The following is a description of a gene set: Genes down-regulated in dendritic cells versus macrophages sorted as ITGAX int and EMR1 high. from publication Rivollier A, He J, Kole A, Valatas V, Kelsall BL (PMID 22231304) Dendritic cells (DCs) and macrophages (MPs) are important for immunological homeostasis in the colon. We found that F4/80hi CX3CR1hi (CD11b+CD103-) cells account for 80% of mouse colonic lamina propria (cLP) MHC-IIhi cells. Both CD11c+ and CD11c- cells within this population were identified as MPs based on multiple criteria, including a MP transcriptome revealed by microarray analysis. These MPs constitutively released high levels of IL-10 at least partially in response to the microbiota via an MyD88-independent mechanism. In contrast, cells expressing low to intermediate levels of F4/80 and CX3CR1 were identified as DCs, based on phenotypic and functional analysis and comprise three separate CD11chi cell populations: CD103+CX3CR1-CD11b- DCs, CD103+CX3CR1-CD11b+ DCs and CD103-CX3CR1intCD11b+ DCs. In non-inflammatory conditions, Ly6Chi monocytes differentiated primarily into CD11c+, but not CD11c- MPs. In contrast, during colitis, Ly6Chi monocytes massively invaded the colon and differentiated into pro-inflammatory CD103-CX3CR1intCD11b+ DCs, which produced high levels of IL-12, IL-23, iNOS and TNF. These findings demonstrate the dual capacity of Ly6Chi blood monocytes to differentiate into either regulatory MPs or inflammatory DCs in the colon, and that the balance of these immunologically antagonistic cell types is dictated by microenvironmental conditions. studied in species Homo sapiens Human Gene Set: GSE27859_DC_VS_CD11C_INT_F480_HI_MACROPHAGE_DN, and this is the list of marker genes: CCT2, TOMM20 (translocase of outer mitochondrial membrane 20), DIP2A, CLN6, BANK1, CGGBP1, TCF7L2, EIF4EBP2, TTC7A, GET3, CTPS1, MRPL41, ATP5IF1, TMEM205, CES2, CATSPERD, VEGFB, SIKE1, MAN2A1, OSBPL7, MAP1LC3A, PMPCA, SAMM50, C1QBP, RNF4, ELMO1, PPARG, MST1, PIGM, ALDH9A1, AP4E1, UBFD1, RASSF5, SMC4, UCHL3, SUCLG2, CLASP1, FBXO5, TMX3, SPCS2, SVIP, ACAP3, PHF3, PPP1R7, HMGN2, RPL29, TSPAN32, CAMK1, SPAG11B, CALM3, LPCAT3, SLC16A9, MRPL39, CENPN, SFXN1, SLC25A36, SGCB, HSPA9, MBNL3, SORT1, SORD, NAPEPLD, INPP5A, ADIPOR1, BLVRA, SPSB2, EXOSC5 (NCBI Gene Id 56915), SLC22A18, FKTN, NLN, TSPAN14, GPR137B, RPP40, FBXO36, ATXN10, FGD4, MYO5A, CDC34, NR2F6, TCEAL9, GFI1B, COPZ2, NEK6 (NIMA related kinase 6), SAMD5, SFT2D1, RAB1B, TMEM141, ETHE1, RPL35A, ACD, EIF3H, MAOA, ADGRL2, ACAA2, NRG4 (NCBI Gene Id 145957), ANAPC10 (NCBI Gene Id 25866), KYAT3, ANP32E, ZHX1, ALDH1L1, IL18, EMC2, PDXK, PLIN3, GNL3L, RPS6KB1, AURKAIP1, NSUN3, SNX15, CD24, TERF2, PSAT1, ANO6, ATP6V0D2, PRMT7, TUBGCP2, PTPN12, MREG, MGAT4B, SUPT20H, CDH18, CAMK2D, PITRM1, DHRS3, ABHD5, TMEM38B, ELMO2, C2CD2L, MATR3 (matrin 3), SPP1, MYO6, SEC24A, CENPP, HMGB1, ARPP19, ABL2, HACD1, CUTA, NCKAP5L, DAP3, PAK1IP1, DOCK5, MAST3, POLH, AMDHD2, FIGNL1, PURB, FLOT1, WWP1, TARS1, CDC14B, MRI1, SLC41A3, SSU72, SLC35C2, DOLPP1, PEX10, DCUN1D4